Given this list of marker genes COL4A6, CCDC3, ME1, PRICKLE2, PEX16, MAGI1, TMEM160, COL4A4, RCN2, NCAM1 (neural cell adhesion molecule 1), CYBRD1, TOMM34, IER3, CITED2, EPB41L4A, STK19 (serine/threonine kinase 19), MCL1, MSX2, SOX2, CLCA2, TNFRSF12A, ARHGEF12, NR1D1, TSPAN5, CRIM1-DT, DMRTA2, HSPG2, KIAA1671, CAPN2, PLCD3, STK17A, NEBL, MFAP5, SLC12A2, PROX1, TFRC, DYNC1I1, BNIP3, PALS2, ALPK2, LMCD1, SLC7A8, ERICH5, DDIT3, CARHSP1, DARS1, PDAP1 (PDGFA associated protein 1), PHGDH, VEPH1, SFRP1, TMEM106B, FGFR3 (NCBI Gene Id 55546), PLCH1, NQO1, TRPM3, ACTG1, MPRIP, TSLP (thymic stromal lymphopoietin), AJUBA, CERCAM, KLF10, CCDC51, CRB2, DCBLD2, F2R, S100A6, PNMA1 (NCBI Gene Id 9240), MLF2, RND3, DDAH1, PGK1, UQCRFS1, HSPB2, DKK3, P4HA2, PARD6G (par-6 family cell polarity regulator gamma), CCDC80, NECTIN3, WLS, THY1, PGM1, SDC2, CHRDL1, CHPF, S1PR3, SLIT3, DGKG, DNAJC6, ADIRF, SLC36A4, EGLN3, ELMOD1, GGA2, GCSH, LDHA, COLGALT2, SIX3, ENO2, TUSC2, PDGFRA, GPER1, PKM, here is a description of the gene set: Occular cell types curated from Gautam and Hamashima et al. Multi-species single-cell transcriptomic analysis of ocular compartment regulons Human Gene Set: GAUTAM_EYE_IRIS_CILIARY_BODY_CILIARY_BODY_CELLS studied in species Homo sapiens from publication Gautam P, Hamashima K, Chen Y, Zeng Y, Makovoz B, Parikh BH, Lee HY, Lau KA, Su X, Wong RCB, Chan WK, Li H, Blenkinsop TA, Loh YH (PMID 34584087)